The following is a description of a gene set: studied in species Homo sapiens from publication Konuma T, Nakamura S, Miyagi S, Negishi M, Chiba T, Oguro H, Yuan J, Mochizuki-Kashio M, Ichikawa H, Miyoshi H, Vidal M, Iwama A (PMID 21540074) Each fraction of mouse hematopoietic cells was purified by cell sorting from bone marrow of 8-week-old C57BL/6 mice, and its gene expression was analyzed. Genes down-regulated in comparison of neutrophils versus monocyte macrophages. Human Gene Set: GSE27786_NEUTROPHIL_VS_MONO_MAC_DN, and this is the list of marker genes: DYNLL2, TLR1, ACTL6A, SRSF7 (NCBI Gene Id 87459), AIRN, MTHFD1, TRAK1, TIMM8A, MSI2, BIK, PPP2R3A, COQ2, AP1AR (NCBI Gene Id 55435), CENPH (centromere protein H), SHH, TMEM86A, ZFAND2A, NBDY, LAMB3, MAP3K20, DSCC1, NUDT1, DTWD1, AKIP1, EIF3I, BOLA3, RPL10, RPL35, RAD51AP1, ELF5, ZNF593, SGO2, GPAT4, SH3TC1, SAAL1, DUS3L (dihydrouridine synthase 3 like), SHMT2, EIF3A, SRP72, TIGD2, LAS1L, EPRS1, CPQ, HCFC1, CKB, RPS8, MRPL52, GINS3, BLVRA, IL15RA, EEF1AKMT1, RIMBP3C, NRXN1, MS4A2, PKN1, NAF1, ERG28, MYL4, MCM9, ZNF326, ZNF511, SNHG32, GSTA5, PRICKLE2 (prickle planar cell polarity protein 2), PRKCSH, ORC6, SEC11A, SMARCA5, DHRS4, CEMIP, CP, RFC4, WDR11, RPL26, SYNGR1, MRPL2, POLK, ZBTB48 (zinc finger and BTB domain containing 48), PDIK1L, LAMC2, SIGIRR, ERCC6L, RRP15, AP4E1, COPS7A, CPSF1, ANKMY2, HRG, MOGS, RBM48, ATP1B1, AARS1, NAA40, CHST14, ZNF771, TFPI2, PRIM1, RPL18A, POLR3K, P2RX4, CALHM6, PTRHD1, ASB5, CCDC38, GNPDA2, SPOCK2, GGA2, TMEM107, GINS1, UAP1, PPFIA4, IFT57, FKBP2, PNPT1, SNX5, PANK4, TRIM27, MLKL, POLR2C, KCTD16, FDX1 (NCBI Gene Id 2230), TBC1D9, LRRC40, ST8SIA6, SS18, HAT1, EEF1D, PPFIA1, DNA2, DNAJC3 (NCBI Gene Id 5611), ZNF639, DCUN1D2, NEB (NCBI Gene Id 4755), TEKT1, LMLN, TSSC4, CTSW, CDC6, FEN1, ENTREP3, CCNF, PELP1, BHLHE40, FXR1, LDLRAD3, KCNK6, WDR76, SEMA6C, BRCA2, REEP6, ATP10A, BMS1, CCHCR1, CCDC102A, DPY19L1, TSHZ1, NUP155, DNAAF2, PIGA, RPS7, BSPRY, SOX30, CHD1, PRKAR2A, TMEM129, PTPN22, CEP135 (centrosomal protein 135), SIRT1, SLC7A1, ARK2C, MGARP, PSAT1, APOE (NCBI Gene Id 99), BRCA1, SUCLG2, NOP56 (NOP56 ribonucleoprotein), AARSD1, EIF3J, RPLP2, LETMD1, OSBP, TRA2B, HOXC10, NUDT21, POC1A, NCOA7, NOL11, ERAP1, HADH, LARP1, ACD, RPL28, CUL5, WDR75, FIGNL1, GPR180, CSDC2, DTNBP1, NIPAL2